The following is a description of a gene set: studied in species Homo sapiens Human Gene Set: GSE13522_CTRL_VS_T_CRUZI_BRAZIL_STRAIN_INF_SKIN_DN To investigate the early host response triggered by three different strains of Trypanosoma cruzi at a local infection site, changes in host gene expression were monitored in a murine intradermal infection model using Affymetrix oligonucleotide arrays. Robust induction of IFN-stimulated genes (ISGs) was observed in excised skin 24 hours post-infection where the level of ISG induction was parasite strain-dependent with the least virulent strain triggering a muted IFN response. Infection of mice immunodepleted of IFNγ-producing cells or infection of IFNγ-deficient mice had minimal impact on the IFN response generated in T. cruzi infected mice. In contrast, infection of mice lacking the type I IFN receptor demonstrated that type I IFNs are largely responsible for the IFN response generated at the site of infection. These data highlight type I IFNs as important components of the innate immune response to T. cruzi the site of inoculation and their role in shaping the early transcriptional response to this pathogen. We used microarrays to detail the local host transcriptional response to intradermal T. cruzi infection in WT mice and mice depleted of NK cells, or deficient in IFN-gamma or type I IFN responses. Additionally we compared the local host-transcriptional response generated to infection with 3 different strains of Trypanosoma cruzi (Y, Brazil, and G). from publication Chessler AD, Unnikrishnan M, Bei AK, Daily JP, Burleigh BA (PMID 19201883) Genes down-regulated in skin from BALB/c mice after injection of: control versus Trypanosoma cruzi (strain Brazil)., and this is the list of marker genes: PIWIL4, C14orf119, TFAP2C (NCBI Gene Id 7022), IHH, FXR2, TPPP3, CEP97, TM6SF1, MBTD1, TNS3, ADGRF1, SCML4, CHRNB4 (NCBI Gene Id 1143), CERS6, RGS5, ALS2, RASSF7, AGO3, SLC4A3, GABRG3, NPNT, ZNF474, ADIPOR1, EDA, MINDY2, CD53, YTHDF1, ANK2, MFN1, OPRK1, GHRH, PTK7, EMX1, CTF1, MDGA1, SLC25A37, RAI1, TMCO5A, SIAH1, CALCRL, WWC2, VAT1L, ZIC2, NPC2, EPHB3, ASPRV1, NES, TMEM151A, KLRG1, BBOX1, SLC6A11, PAWR, BTBD3, CBFA2T3, CHIC1, RAB21, PDZRN4, CD74, GIPC1, STAU1, CX3CL1, INSC, HLA-DQA1, HID1, CD72, ABTB2, DTX3 (NCBI Gene Id 196403), TRIM7 (NCBI Gene Id 81786), MGRN1, USP7, ARAP3, RFLNB, TERB2, WNT5B, MEIG1, RNF157, ZFYVE28, CSTA, AGFG1, CDYL2, FBXL16, FAAP100, DUSP23, RGS13, ABCA1, LRP3, FXYD6, PHF21A, DZIP1, SEMA6A, ERBB2, CLPS, ICMT, SCNN1A, PARVA, PXMP4, RGS9BP, TCF21, RAB13, PCIF1, ALS2CL, C1QC, BAG2, TRABD2B, ATP8B4, TDRP, TPD52L1, EPHA5, TEP1, TMEM37, PADI6, POLR3F, VGLL1, SLC30A8, ATP6AP2, DDN, STMP1, POU2AF1, PPP1R1A, USP25, CDH9, ARMCX2, EIF2B4, EDNRB, GCGR, ILDR1, CD247, RWDD2B, CYTL1, SLC35F1 (NCBI Gene Id 222553), SEMA4C, SPAG17, RB1 (RB transcriptional corepressor 1), EDARADD, ADH7, UTF1, GDF3, STYXL1, PPP6R2, HTRA3, ITGB5 (NCBI Gene Id 3693), HES5, CHML, ACOD1, HACD1, CCR7, SERPINA6 (NCBI Gene Id 866), PDE5A, FNTB, SPOCK1, CYLC2, NFE2L2, FAT1, CHD7, UNC5A, GTF2I, PSMD3, CHCHD6, APOLD1, CALB1, MYLK3, UNC13B, DNAH17, CD34 (CD34 molecule), C10orf120, SERINC2, TOMM34, FARSB, ADRA2B, PDZD4, ATOH8, TPO, SEMA4A, TPSB2, BCL6, NOVA1, PCYT2, GGT5, LRP1, GAB2, SATB1, STIM1, PRRX1, CMA1, SEMA6C, OTOA, ASTN1, SCG3, DHX58, HS2ST1, HCK, ZBTB43, EN2, ARHGEF6, EEIG1, PDE3B, SLC12A8, VRTN, PRKAB2